Given this list of marker genes Arhgap6, Taok3, Lbr, Arhgap15, Racgap1, Arap2, Amigo2, Arhgap17, Vrk2, Cybb, Pak2, Rbm39, Arhgap5, Cav1, Nckap1, Cdc42ep1 (CDC42 effector protein 1), Wasf2, Arap3, Wasf1, Trio, Arhgap35, Slitrk5, Git2, Bcr, Abi2, Dock10, Diaph3, Git1, Ncf4, Nox3, Emd, Arhgdib, Jag1, Srgap2, Lman1, Swap70, Vav2, Pak4, Rac3, Abr, Vangl1, Snap23, Stbd1, Cyfip1, Prex1, Mcf2, Dsg2, Abl2, Baiap2, Rab7, Arhgap42, Vamp3, Itgb1, Abi1, Depdc1b (NCBI Gene Id 218581), Ophn1, Cyba, Noxa1, Tfrc, Slitrk3, Arhgap32 (Rho GTPase activating protein 32), Noxo1, Pak1, Cdc42, Pik3r2, Ocrl, Nox1, Erbin, Nhs, Mpp7, Slc1a5, Arhgap21, Brk1, Syde1, Fermt2, Mcam, Rapgef1, Pik3r1, Epha2, Arhgap26, Arhgap1, Esyt1, Arhgap39 (NCBI Gene Id 28124), Ncf1, Lamtor1, Baiap2l1 (NCBI Gene Id 66898), Ncf2 (neutrophil cytosolic factor 2), Pgrmc2, Nckap1l, Ykt6, Garre1, here is a description of the gene set: RAC3 GTPase cycle Mouse Gene Set: REACTOME_RAC3_GTPASE_CYCLE species: Mus musculus